Given this list of marker genes AP4B1, PGA5, CTSL, GH1, CTSK, IL12B, NGF, AP4M1, LRP2, IL12A (NCBI Gene Id 3592), APP, PDLIM4, RAB32, PRL (NCBI Gene Id 5617), LRPAP1, PTPN2, SFTPB, RAB38, CSH1, PRLR, B2M (beta-2-microglobulin), LGMN, CTSS, AP4E1, LNPEP, APOB, CD63, PGA4, PGA3, JAK2, AP4S1, SFTPC, CTSD, PRF1, CTSH (cathepsin H), NAPSA, PTPN1, GH2, INS, CTSB, here is a description of the gene set: The volume enclosed by the membrane of an endosome. species: Homo sapiens Human Gene Set: GOCC_ENDOSOME_LUMEN